Given this list of marker genes CTC1, VDR, PORCN (NCBI Gene Id 65017), NOTCH2, TERC, USB1, RTEL1, NOP10, AMER1, DKC1, AXIN1, TRPV4, NHP2, SLC29A3, TNFRSF11B, PARN, WRAP53, PLCB3, TYMS, TCIRG1, TINF2, TNFRSF11A, LIFR, NPM1, TERT, here is a description of the gene set: studied in species Homo sapiens Human Gene Set: HP_ABNORMAL_METAPHYSEAL_TRABECULATION Abnormal metaphyseal trabeculation An abnormality of the pattern of trabecula (small interconnecting rods of bone) in a metaphyseal region of bone.